The following is a description of a gene set: studied in species Homo sapiens Human Gene Set: GOBP_SODIUM_ION_TRANSMEMBRANE_TRANSPORT A process in which a sodium ion is transported from one side of a membrane to the other by means of some agent such as a transporter or pore., and this is the list of marker genes: TPCN1, SLC4A9, PKD2, SLC6A16, SCN9A (NCBI Gene Id 93955), SLC17A1, SLC5A1, SCNN1A, NALCN, SLC34A3, ATP4B, MCOLN1, SLC20A1, DMD, SLC38A4, SLC6A15, SLC24A4 (solute carrier family 24 member 4), SLC38A1, SLC6A5, MCOLN3, CNGB1, SLC5A2, SLC13A2, ASIC1, SCN7A, HCN4, FXYD6, SLC24A2, SLC24A5, PRKCE, STK39, WNK4, KCNK9, SLC6A17, SLC41A1, RANGRF, SLC6A9, SLC12A3, CNGA3, SLC5A10, SLC6A11, GRIN2A, SCN4B, FXYD5, SLC8A1, SLC12A2, SLC6A19, SLC6A6, SLC13A4 (solute carrier family 13 member 4), SLC28A3, SLC38A2, SLC9B1, GRP, SLC9C1, BPIFA1, ASIC3, SLC12A1, SNTA1, WNK3, ATP1A4, SLC17A2, KCNK3, ASIC2, CHP1, PKD2L1, SLC17A6, SLC9A1, ATP12A, SLC6A2 (solute carrier family 6 member 2), SLC9B2, SCN5A, ATP1B2, SLC6A20, PTPN3, COMMD1, SLC4A4, ATP1A2, NOS1, SLC41A3, SLC5A9, SLC17A7, CNNM4, FXYD7, FXYD6P3, SCN2B, SLC20A2, KCNK1, SCN10A, WNK1, UTRN, FGF12, SLC5A11, SLC9A4, SLC9A7, SLC24A1, TRPM2, NEDD4L, SLC4A8, SLC5A3, SCNN1G, SLC9A6, HCN1, SLC5A6, SLC23A1, SLC4A11, SLC17A8, DLG1, SLC34A1, SCN11A, ATP1B3, ATP4A, SCN1A (NCBI Gene Id 6323), AGT, SLC8A2, MIR448, ATP1A1, SHROOM2, SCNN1D, HCN3, TESC, SLC6A7, SLC6A12, ATP1A3, SLC13A3, SLC9A3 (solute carrier family 9 member A3), SCNN1B, ACTN4, SLC38A5 (NCBI Gene Id 92745), FXYD4, SLC9C2, SLC8A3, HCN2, CAV3, SLC34A2, ASIC4, TRPM4, SLC9A9, SLC5A4, SCN8A, FXYD2, FXYD3, SCN1B, NPPA, SLC13A5, SLC6A8, FXYD1, P2RX7, TRPM5, SLC6A14, WNK2, SLMAP, SLC9A8, SLC6A18, GRIN1, PCSK9, SLC6A1, FGF13, SLC9A5, TRPV3 (NCBI Gene Id 201131), SLC9A2, SLC5A5, SLC17A3, SLC4A7, SLC8B1, SLC13A1, SCN3B, SCN3A, CAMK2D, SLC6A3, SLC4A5, MIR192, CNGA1, OSR1, SLC6A13 (solute carrier family 6 member 13), ATP2B4, MIR24-1, ATP1B1, SLC4A10, SCN2A, SLC17A4, SLC24A3, ASIC5, SLC6A4, ANO6, SCN4A, TPCN2